Given this list of marker genes PUS10, CAMSAP2, TMEM161B, EI24, ACOX1, SIPA1L1, PTPN9, ITPR2, MTIF2, YTHDC1, CORO7, SRPRA, F2, DYNC1I2, GPHN, BIVM, USP33, FBXO32, MAP3K4, ZMYM4, PPIP5K2, CCDC47, ZNF106, DENND6A, CHCHD3, RSU1, MGA, HECTD2, SYT13, MAT2B, CCDC125, PCCA, CRBN, GFM1, RELL1, DNAJC10, CD81, TTC3, ATXN3, ACAA2, SBF2, DHX36, LMBRD1, SERTAD4, VEZT, RAPGEF2, ZXDC, ITM2A, UTP14A, KIFAP3, KLHL24, ETS1, JAK2, LRRCC1, PTK2B, PGAM2, BBS9, UACA, MAGED1, BLTP3B, RNF145, XRCC5, CTNND1, ZDHHC13, DNAJB4, MICAL3, RCBTB1, IRF4 (interferon regulatory factor 4), ARID4B, SH3KBP1, TAF2, GSS, DCTN6, IGFBP4, SINHCAF, SHISA5, PEX2, SPTLC2, MBNL2, ZBTB38, GGCT, MSH3, ZMYM2, AGL, EIF3C, TMEM106B, ITGB1, FRRS1, YLPM1, GALK2 (NCBI Gene Id 2585), GNPNAT1, FAM107B, HELB, HEXIM1, LYPLA1, AKAP9, LIN9, IL6ST, PRMT7, NF1, CHMP2B, CLIP1, DDIT4, FBXO38, SPRED2, ST7L, SLC25A36 (NCBI Gene Id 55186), FJX1, ARHGAP9, PNRC2, SWAP70, FBXL20, LPCAT3, AXIN2, EGLN3, IL1RL2, DUSP10, NRIP1, MYLIP (NCBI Gene Id 29116), PHKB, NDFIP1, EIF4G3, SFMBT2, PPP6R2, DHX33, EMB, SMO, MAP4K4, CHD7, VPS53, HIVEP2, IKZF1, CCR4, LRRC66, GLB1, FUT10, GNL2, OCRL, ECI2, DPP4 (NCBI Gene Id 1803), IKZF3, CLOCK, NFXL1, NEU3, BCAP29, GUF1, PRKD2, ANO10, ATF6, AAK1, GFRA1, PHLDA1, RNF2, GIMAP4, WDR41, GBE1, PRMT9, BTLA, SPG11, IBTK, SEC62, ARHGEF3 (NCBI Gene Id 50650), PDGFRB, MGRN1, CNIH4, JARID2, ACTR1A, DUSP22, AGFG1, WDR11 (NCBI Gene Id 79207), PRKAR2A, MBTD1, RABEP1, IKZF2, here is a description of the gene set: species: Homo sapiens from publication Chan G, Bivins-Smith ER, Smith MS, Yurochko AD (PMID 18003728) Human Gene Set: GSE9601_UNTREATED_VS_NFKB_INHIBITOR_TREATED_HCMV_INF_MONOCYTE_DN Genes down-regulated in monocytes after HCMV infection: untreated versus BAY 11-7082. Human cytomegalovirus induces a pro-inflammatory monocyte following infection and we have evidence that NF-κB and phosphatidylinositol 3-kinase are key mediators in this early activation. To begin to address how these signalling pathways are responsible for the rapid activation of infected monocytes, we examined the role these pathways played in the transcriptome of infected monocytes. Global transcriptional profiling using cDNA microarrays revealed a significant number of genes, including inflammatory genes, were regulated in a NF-κB- and/or PI(3)K-dependent manner, identifying these pathways as key cellular control points in the conversion of monocytes to an activated pro-inflammatory state following HCMV infection.